The following is a description of a gene set: Any process in which a cell is transported to, and/or maintained in, a specific location. species: Mus musculus Mouse Gene Set: GOBP_LOCALIZATION_OF_CELL, and this is the list of marker genes: Pomgnt1, Fkrp, Ankrd11, Cd2ap, Bhlha15, Large1, Slc48a1